The following is a description of a gene set: Distal peripheral sensory neuropathy Human Gene Set: HP_DISTAL_PERIPHERAL_SENSORY_NEUROPATHY Peripheral sensory neuropathy affecting primarily distal sensation. species: Homo sapiens, and this is the list of marker genes: MT-TH, MT-CO1, MT-ND6, MT-CO3, MT-TW, MT-ND1, MT-TL1, MT-TF, IBA57, GSN, SPG11, HADHB, MT-CO2, DKK1, MT-ND5, HADHA, MT-ND4, MT-TQ, MT-TS2